The following is a description of a gene set: In mammalian cells, many antioxidant defence systems exist which protect cells from subsequent exposure to oxidant stresses. One antioxidant is glutathione (GSH), a tripeptide present in virtually all cells that regulates the intracellular redox state and protects cells from oxidative injury. It is metabolised via the gamma-glutamyl cycle, which is catalysed by six enzymes. In man, hereditary deficiencies have been found in five of the six enzymes. Glutathione synthetase deficiency is the most frequently recognised disorder. Defects in GSS can cause glutathione synthetase deficiency (GSSD aka 5-oxoprolinase deficiency, MIM:266130), a severe autosomal recessive disorder characterised by an increased rate of haemolysis, 5-oxoprolinuria, CNS damage and recurrent bacterial infections. In this condition, decreased levels of cellular glutathione result in overstimulation of gamma-glutamylcysteine synthesis and its subsequent conversion to 5-oxoproline. Glutathione synthetase deficiency can be classed as mild, moderate or severe (Ristoff & Larsson 2007, Aoyama & Nakaki 2013). species: Homo sapiens Reactome Pathway: Defective GSS causes GSS deficiency part of: Metabolic disorders of biological oxidation enzymes, and this is the list of marker genes: GSS